Given this list of marker genes GFI1B, RFPL1, ANAPC7, TICRR, CENPF, PKHD1, SNX33, DPF3, LZTS2, TEX14, HSPA2, CNTROB, BRCA2 (NCBI Gene Id 82716), CACUL1, NES, JADE1, AURKA, BCL6, L3MBTL1, CUL3, TMOD3, ECT2, SMC1A, INPPL1, SEH1L, CPSF3, PRKCA, CCNB3, MZT1, KIF14, MIR133B, MIIP (migration and invasion inhibitory protein), MIR26A1, FGFR1, RPTOR, NCAPH2, MIR362, RCC1, BAZ1B, CDK2AP2 (NCBI Gene Id 10263), NFIB, TACC1, SMARCE1, DCUN1D3, CLASP1, RNASEH2B, ENSA, HINFP, KIF22, APPL1, ABRAXAS1, EXOC6, PHF8, ZNF830, BANF1, ECD, CKS2, E2F3, EIF4G1, TGFA, CALM2, SPRY2, TACC3 (NCBI Gene Id 10460), MIR451A, BCL7C (NCBI Gene Id 9274), BID (NCBI Gene Id 637), PAX6, E2F1, CHMP2A, NCAPG, TTK, CCDC61, CENPC, INO80, ZFYVE19, EDN3, LATS2, RAB11FIP3, PPP1CC, SMPD3, SPDYA, RAE1, SIRT1, ZFYVE26, UHRF1, BCL2, DCTN1, SMARCB1, PABIR1, TMEM14B, CTDSPL, SNX9, MIR137, CHMP4B, EME2, PIN1, EME1, NCAPH, FBXL15, INHBA, POLDIP2, RAD50, ARF6, BRD7, ACTB (NCBI Gene Id 60), MCM4, USP44, TAOK1, APC, DACT1, RMDN1, EXOC1, AMBRA1, RPS27L, WEE1, TOM1L1, TIPIN, CDKN1B, CDKN3, EML3, USP37, CFL1, CCNP, RBL2, NCAPD3, TAOK2, DYNC1H1, TP53, LPIN1, PARP3, USP26, BLM, TAOK3, EXOC5, UBE2I, TRIM39, RTEL1 (NCBI Gene Id 53593), DTL, CEP97, ARID1A, MIR495, KCNH5, ZW10, XPC, STK33, USP22, EXOC4, RAD21, FHL1, CCNB2, CDK6, CDC20, CACNB4, CHMP6, KIF25, RHOA, NSFL1C, MIR133A1, CDT1, CCNE2, CUL1 (NCBI Gene Id 8454), BTN2A2, RRM1, CDK1, CHMP7, WAPL, POLA1, SLFN11, TM4SF5, BABAM2, CDK10, MYH14, IK, DLGAP5, TRIP13, MCM2, CIT, FAM107A, CENPE, BROX, PRC1, DBX2, DLG1, ACTL6B, DDR2, CDK5RAP3, MIR638, FOXN3, CCNO, CUL4B, CCNB1, CLTC, BCL7A, PBX1, CDKN2A, HTT, WDR62, PAFAH1B1, CKAP2, MIR221, SMARCC2, STK35, WRAP73, ESPL1, MIR29C, RCC2, EPGN, CHMP1B, SPAST, EREG, CENPH, NEUROG1, PLK1 (polo like kinase 1), KIF11, FGF8, AURKB (aurora kinase B), SAPCD2, ATR (ATR serine/threonine kinase), IQGAP2 (IQ motif containing GTPase activating protein 2), MBTPS2, RTF2, EML1, RAB11A, MAP9, CCNG2, NBN, ZNF365, RAD51C, DIS3L2, TPR (NCBI Gene Id 7175), EGFR, NUMA1, PHF10, CAMK2A, ZNF655, CCNE1, BRSK2, BTC, DCTN2, ID2, CHMP4BP1, CCL2, WNK1 (WNK lysine deficient protein kinase 1), EXOC6B, MTBP, RIOK2, MNAT1, CHMP3, PLK3, ANAPC1, NDC80, CDK3, IGF2 (insulin like growth factor 2, NCBI Gene Id 492304), DRD3, ATF2, E2F7, ROCK1, NDE1, FBXO5, HSPA1A, MIR520H, RAD9B, KIF20A, SPTBN1, UIMC1, EIF4E, TTN, MIR19B1, AKAP8L, MTMR4, CHMP4A, HEXIM2, CDKN2C, RPL24, POLE, IST1, TRIAP1, RPA2 (NCBI Gene Id 6118), CCNA2, BRCC3, ADAM17, CHFR, DPF2, ARF1, KIF2A, ILK, CDC42, JTB (NCBI Gene Id 23561), PPM1D, MIR520A, SUN2, UBE2E2, UBXN2B, CDC14B, CTC1, MIR214, NUDC, CUL2, CDK2, ZC3H12D, NCAPD2, TOPBP1, SYF2, INSR, DDB1, PRICKLE1, BOD1, BUB1B, ARHGEF10, CEP85, SMARCA4, CCNF (NCBI Gene Id 899), KAT5, EIF4EBP1, CALM3, ZWILCH, NUSAP1, SPC24, CCNA1, RAD9A, ZWINT, SPAG5, MTA3 (NCBI Gene Id 731342), BBS4, PLCB1, PDGFRB, EDN1, SNX18, PPP1R9B, NDEL1, APPL2, KLF11, SKA1, ARPP19, SMARCD2, RRM2, INCENP, MCM3, MAP10, EXOC8, DONSON, CCSAP, SMARCA2, TNKS, MTMR3, PKD1, KLHDC8B, TACC2, SPDL1, GJA1, INTS3, HDAC3, DYNC1LI1, NSMCE2, BMP4, PRKCB, MUC1, LATS1, MYO16, EZH2, TAF10, ATAD5, UNC119, HOXA13, AKT1, MCM6, CUL7, TTC19, GINS1, HASPIN, UBE2A, INS, LSM14A, DGKZ, CTDP1, ANXA1, CCNJ, TAF2, KPNB1, SON, CDC25C, REEP4, SPC25, KATNB1, PKIA, ACVR1B, FBXW11, MIR222, CRLF3, EXOC2, CDC25A, FOXM1, LCMT1, MSH2, RINT1, SMARCD1, FSD1, KIF18A (kinesin family member 18A), NIPBL, PTEN, H2BW1, CHMP5, CAV2, IL1B, PPP1R10, PKMYT1, MEPCE, GSPT1, MIR15A, ATM, MAP1S, PPME1, LSM11, PHIP, NFE2L1, MRNIP, SMC3, RTKN, PDIK1L, SMC4, IGF1 (NCBI Gene Id 3479), MIR208A, ZFP36L2, INTS13, CCNY, PPP6C, MYC, DMRT1, STIL, RAB35, CDK14, CDK4, CCND2, FAM110A, PLK5, PCNA, PRP4K, PPP3CA (protein phosphatase 3 catalytic subunit alpha), TPRA1, MARK3, PLRG1, FLNA, RPS6KB1, MIR195, DCDC1, TPD52L1, MDM2, CCND1, NEK11, RAD51B, CHEK2, RHOU, PIM2, RACGAP1, OBSL1, TREX1, EGF, KNSTRN, STAMBP, PBRM1, GOLGA2, SEPTIN6, KIF2C, MBTPS1, KCNA5 (potassium voltage-gated channel subfamily A member 5), CEP126, TGFB1, NUP62, PLK2, TOM1L2, SDE2, SH2B1, CCNI2, ACVR1, PDCD6IP, SBDS, ID4, SMARCA5, MAD2L2, PSME1, ARID2 (AT-rich interaction domain 2), KLHL22, PTPA, CENPA, SIRT2, SETD2, BRCA1, PHOX2B, CCDC57, BIRC5, KDM8, CDC14C, CYP1A1, ENKD1, KIF20B, BUB3, FGF10, RGCC, NAA50, KMT2E, TUBG1, OFD1 (NCBI Gene Id 8481), NAE1, BARD1, RANBP1, MIR892B (NCBI Gene Id 100126307), NME6, LIG1, RAD17, ARID1B, MCPH1, MIR30C2, MIR372, STAG2, DBF4B, NSL1, CDCA2, MISP, CDKN1C, TUBG2, GPSM1, PTPN6, TFAP4, USH1C, VCP, PINX1, INIP, SPICE1, CCDC8, DRG1, CDC16, MIR29A, RANGRF, KAT2B, NCAPG2, SKA2, SPHK1 (sphingosine kinase 1), ZFP36L1, DPF1, RDX, RIPOR2, MYB, SASS6, AKAP8, KMT5A, CEP192, KLHL18, PRKDC, AAAS, POC1A, KHDRBS1, ANAPC11, CKAP5, SMARCD3, FBXW5 (NCBI Gene Id 54461), RRS1, CD28, CENPJ, DNA2, USP8, UBE2C, ACTL6A, AURKAIP1, CUL5, ZNF207, BCL7B, CDC45, GPNMB, DNM2, CLASP2, RASA1, AFG2B, HNRNPU, CTDSP1, IL1A, CDC14A, CCND3, SIN3A, CUL4A, BRD4, TFDP1, FOXO4, NEK2, PHF13, DDX3X, RFWD3, PDGFB, CHMP2B, DYNLT1, BUB1, FZR1, KIF18B, FBXO7, IQGAP3, PSMG2, ORC1, PPP2R2D, ABCB1, BCCIP, TNF, CDC34, BRSK1, CENPI, BCAT1 (NCBI Gene Id 586), CDCA8, DAPK3 (death associated protein kinase 3), KIF15, RHOC, EPS8, EXOC7, BMP7, BORA, MBLAC1, MIR515-1, GPR132, MIR15B, RECQL5, CDCA5, TCF3, MIR16-1, RHOB, PSRC1, WNT10B, RBBP8, CHMP4C, RB1, TFDP3 (transcription factor Dp family member 3), UBD, CDK5RAP2, GPSM2, PPP2R1A, BECN1, MASTL, FBXO43, EXOC3, IER3, FANCD2, TRIM36, PIBF1, KIF4A, PRAP1, KIF23, CCNJL, MIR193A (NCBI Gene Id 406968), STOX1, GTPBP4, CDC6, MAP4, EFHC1 (NCBI Gene Id 94915), CDC23, PSME3, XRCC3, VPS4A, RBL1, RAD51, CCDC66, ERCC3, RRM2B, KLF4, ZNF324, HUS1B, CENPK, ANAPC5, DCTN6, MYH10, SKP2, KANK2, TK1, CHEK1, MRE11 (NCBI Gene Id 4361), ANKRD53, PDXP, MYBL2, GIGYF2, BABAM1, CDKN2D, CHMP1A, CCNG1, ANLN, WAC, ANAPC4, VPS4B, REEP3, STAG1, LRP5, MAP3K20, CTDSP2, NABP1, EML4, ADAMTS1, CDK7, DBF4, MAD1L1, SMARCC1, TENT4A, AIF1 (allograft inflammatory factor 1), GNAI1, NABP2, TRIM71, ANKRD17, NUF2 (NCBI Gene Id 83540), CDC27 (cell division cycle 27), MDC1, SMC2, PKD2, PPP2CA, CCNH, ERCC2, CDC73, ANAPC15, TERT, NFIA, HUS1, NOP53, MELK, MIS12, CHAMP1, NEK6, HECW2, ITGB1, SKA3, PRMT2, ANK3, KNL1, ANAPC2, KNTC1, PSME2, KIFC1, SPART, CCNI, RAN, GINS3, TPX2, CDC7, MKI67, AVEN, IQGAP1, LSM10 (NCBI Gene Id 84967), FBXL7, ANKLE2, MAD2L1BP, VRK1, CEP55, USP16, MITD1, CUL9, MAPRE1, HSPA1B, ABRAXAS2, SPRY1, NPM2, CLSPN, SENP2, ROCK2, USP29, AURKC, ANKFN1, KIF4B, PRMT5, CDC25B, MIR519D (NCBI Gene Id 574480), CTDNEP1, MUS81, STMN1, ZMPSTE24, MAD2L1, CALM1, TBCE, UBE2S, DUSP1, MIR29B1, PTENP1-AS, KIF3B, GEN1, PIAS1, SETMAR, CDKN2B, ETAA1, SMC5, PCNT, FBXO31, CDKN1A, ARL3, here is a description of the gene set: A process that is part of the mitotic cell cycle. studied in species Homo sapiens Human Gene Set: GOBP_MITOTIC_CELL_CYCLE_PROCESS